Given this list of marker genes AJUBA, SP2, ISLR, HIBADH, LRRC27, RNA5SP378, PCGF3, ELP3, PLA2G6 (phospholipase A2 group VI), CHRNA4, FLAD1, WSB2, ENSG00000179066, ZNF718, LINC02564, CCDC187, FANCG, here is a description of the gene set: Human Gene Set: MYF6_TARGET_GENES Genes containing one or more binding sites for (MYF6) in their promoter regions (TSS -1000,+100 bp) as identified by GTRD version 20.06 ChIP-seq harmonization. from publication Yevshin I, Sharipov R, Kolmykov S, Kondrakhin Y, Kolpakov F (PMID 30445619) studied in species Homo sapiens